Given this list of marker genes UBFD1, SPIC, RSPH10B2, STING1, FCAMR, NAF1, SERPINA10, PTH1R, EXT1, METTL1, EARS2, TMEM150A, MPHOSPH6, ANKMY1, CDH5, MPHOSPH10, MAFF, PUS1, NES, BPIFB1, CMTR2, P4HA2, BRD7, AKAP12, SLC15A4, KCTD11, E4F1, OCLN (NCBI Gene Id 4950), SMARCE1, ATP6V0A2, KIF3B, HSD17B6, LRRIQ1, MAGEA9, PDE1A, RTL4 (retrotransposon Gag like 4), MIR204, CPNE5, SERTAD4BP (NCBI Gene Id 648271), GDAP1, PLPPR5, HEPACAM2, CCDC77, IZUMO4, NOP58, SYCP1, ACAP1, MSI1, TMED10, RCBTB1, PIK3C2A (phosphatidylinositol-4-phosphate 3-kinase catalytic subunit type 2 alpha), UXT, LDHAL6B, PROM1, TRMT61A, TULP3, CXorf38, NIPSNAP1, SLC25A41, HLA-B, GAD2, RAPGEF4, RIOK2, FPR1, UROS, IL1RN, TRIM45, ATAD3A, NGDN, COX18, ADD3, GGT6, SET, MIR148B, PRTN3, CMTM3, SLC30A8, PSD4, SLC44A1, TRIM40, HDAC2, HTR7, TOMM6, ERLIN2, WDR64, PKDREJ, MRPS27 (NCBI Gene Id 64948), GPR61, DCC, IL17RA, SLC11A1, TIMD4, KCNMB2, NEPNP, DNM1L, NXF1 (NCBI Gene Id 10482), KRT6B, DNAJC9, CSTA, ICOS, MCM3AP, CDK20, MIR491 (microRNA 491), REG4, NEFL, RUFY2, MESP2, KRT76, HACE1, TMEM69, MIR219A2, EXOC4, KCNK10, GLRB, MAGEE1, PSMC6 (proteasome 26S subunit, ATPase 6), EWSR1, PPARGC1B, SGCD, ADGRF5, TEKT2, GALR1, IGFBP4, PDLIM4, GATB, DQX1, MYO18A, RABEPK, DAPK1, CFAP206, ENO2, B9D2, CHD3, IKZF5, GDE1, DLEU2, TMEM53, FGGY, STARD5, ETF1, FMC1, POC5, NMT2, ACSS1, ENC1, GOSR2, SF3B3, CDH19, here is a description of the gene set: species: Homo sapiens We used microarrays to detect the primary changes caused by the 'san' mutation in Roquin gene by comparing the gene expression profiles of naive (CD44lo) CD8+ T cell population. Genes up-regulated in CD44 low CD8 T cells: wildtype versus RC3H1 knockout. Human Gene Set: GSE37319_WT_VS_RC3H1_KO_CD44LOW_CD8_TCELL_UP from publication Chang PP, Lee SK, Hu X, Davey G, Duan G, Cho JH, Karupiah G, Sprent J, Heath WR, Bertram EM, Vinuesa CG (PMID 22685317)